Given this list of marker genes Drd1 (dopamine receptor D1), Drd5, Htr2a, Htr2c, Grin2b, here is a description of the gene set: Mouse Gene Set: GOBP_SENSITIZATION An increased in a behavioral response to a repeated stimulus. For example, a shock to the tail of the marine snail Aplysia, to which the snail responds by withdrawing its gill, will result in increased gill withdrawal the next time the skin is touched. species: Mus musculus